Given this list of marker genes TREML1, SOCS2, RAD51AP1, DPYSL4, TMEM102, PRDX1, FAM43A, LTK, ACTR5, KCNA6, SSX5, CD59, NUFIP2, MYF5, OR5E1P, PRH1, HNF4G, UBAP2, TRG-AS1, FA2H, OR2C3, FBXO39, PTMA, SNX30, SERTAD4BP, MIR21, ZYG11A, ZFYVE1, PTPN13, S100A6, SGSM3, PSMB6, GNB1, SPIN2A, DCTN1, TRPC2, EIF6, SLC25A35, TNFRSF18, MAP4K4, NDN, H3C11, PRDM8, GNGT2, ATG16L1, IL17RB, ROR2, CLSTN3, IZUMO1, GZMB, PHF21B, MRPL2, CDIPT, UBE2M, MCMDC2, CCDC63, BHLHE40, MUC4 (NCBI Gene Id 55804), TOP2A, NR2F2, ADAMTSL4-AS2, CMIP, TMEM198, ERN1, MAP2K3, TSSK1B, DOLPP1, PABPC4, CCDC92, PPP1CA, PCNX3, SPAG6, USF1, FAM185A, IRX5, MT1HL1, BMP15 (bone morphogenetic protein 15), ZBTB12, KCNJ11 (potassium inwardly rectifying channel subfamily J member 11), SIVA1, CLIC3, FAM181B, GALM, UPP1, TPRG1L, CHPF, LIN7B, CYP8B1, ZNF554, C9orf152, POLR2G, THAP8, AP2M1, CYP4F2, KLF2, DCP1B, EPAS1, GDAP2, ANGPT4, DSCR10, LMX1A, HPS6, HES2, GZMA, CYTH2, KREMEN1, ABHD15, DBN1, MYOD1, MFSD10 (NCBI Gene Id 10227, major facilitator superfamily domain containing 10), HBQ1, GPNMB, CENPE, TP53I13, IL18RAP, PACSIN2, NDUFA11, S100A10, SLCO5A1, B3GALT1, RRAGA, WDR18, HOXB9, INSL6, NRROS, C10orf62, G6PD, LAGE3P1, STX4, HYCC2, SDHAF1, EPHX4, EOMES, FAM124B, DDRGK1, PLA2G2E, PSKH2, C1QB, ANTXR1, KRTAP4-12, KIF21A, PSMD14, CCDC157, STK32A, KCTD7, USP4 (ubiquitin specific peptidase 4), WDR86-AS1, CD70, CXCR3, CYTH3, EML6, PWWP2B, DRAXIN, FES, PTPN21, SUSD2, SPINK4, LL22NC03-63E9.3, INPP1, CBX2, KCNK17, VRK3, GFRA1, ANXA2P2, CREB3L2, TFAP2E (NCBI Gene Id 339488), PRDM5, ENC1, ZGPAT, LINC01128, SCRIB, PIGT, RUNX2, MRPL58, CLPTM1, NOD2, ENSG00000240207, ISLR2, SCAMP2 (NCBI Gene Id 10066), GAB4, IRF4, SLC25A48-AS1, KDSR, SEZ6L, PRR5, PASD1, CSTB, ETV7, RETSAT, RNASEH1-DT, HSPA1A, here is a description of the gene set: studied in species Homo sapiens Genes up-regulated in comparison of CD4 effector memory T cells versus CD4 CXCR5+ T cells. from publication Chevalier N, Jarrossay D, Ho E, Avery DT, Ma CS, Yu D, Sallusto F, Tangye SG, Mackay CR (PMID 21471443) Human Gene Set: GSE26928_EFF_MEMORY_VS_CXCR5_POS_CD4_TCELL_UP